The following is a description of a gene set: studied in species Homo sapiens Occular cell types curated from Gautam and Hamashima et al. Multi-species single-cell transcriptomic analysis of ocular compartment regulons from publication Gautam P, Hamashima K, Chen Y, Zeng Y, Makovoz B, Parikh BH, Lee HY, Lau KA, Su X, Wong RCB, Chan WK, Li H, Blenkinsop TA, Loh YH (PMID 34584087) Human Gene Set: GAUTAM_EYE_CORNEA_MELANOCYTES, and this is the list of marker genes: ELOVL5, PTMA, TMEM101, SUGT1, NPC2, DUSP14 (NCBI Gene Id 116242), MRPS18B, FIGN, UBE2B, CTSA, PTPN18, YTHDC1, CMTM3, MTURN, CTH, TP53BP2, PTRH1, UBE2D1, SNX3, TUBA1B, PLXNB1 (plexin B1), PRMT2, PSMD13, POLR1F, GNG5, MEF2C, NDUFAF3, RABIF, RPS8, SEM1, MGA, IFRD1, NRCAM, HYCC1, MAP4, GMFB, CYBA, EIF5, TP53RK, COPS6, FADS1, ISYNA1, DYNC2I2, DNAJC8, RPN2, C7orf50, RPL13A, SNRPC, PLIN2, BABAM1, UBALD2, TMED9, OAT, RBM3, ARHGDIA, KLF9, ITPK1, BLVRB, RPSA, ARID5B, RPL18A, CYC1, CHCHD3, SUPT4H1, LIX1L, ABL2, STAT2, RAMP1, CAVIN1, CLEC11A, MRPL28, SLC25A25, YWHAH, MID1IP1, RPL39, CFAP97, TDRD7, RPS26, RSRP1, NR3C1, NDUFAF4, ARHGEF37, POU3F3, CUTA, S100A1, LHFPL2, ALDH7A1, CCDC124, JADE1, ZNF24, LAP3, CDH1, SNRNP25, ADD3, LAMP2, RPL8, STXBP1, DNAJB1, RPS10, CD320, METRN, CHMP1A (NCBI Gene Id 5642), RTN2, CLASP2, FXYD5, NFATC2, PPM1B, RASGEF1B, TMED10, SPP1, EIF4B, KIFC3, RPS11, ISCA1 (NCBI Gene Id 92236), AZGP1, CHCHD2, RASSF3, MYO1C, SDHAF3, CCT6A, MICAL3, RPS3A, DNAJB9, GUCD1, ARL6IP5, MOB1B, LAMTOR4, IFFO1, UBE2S, PGRMC2, XRCC6, WDR18, SERTAD1, DIPK1C, TFPT, JAGN1, OLFM1, PRPF6, NPM1, PA2G4, NUBP2, FUS, CSGALNACT1, NTAN1, ARHGAP42, RPL10, ANKRD39, NAMPT, PLD3, SLC25A11, PSMC2, SRM, DDOST, PSMA7, RPL32, HSF4, C1orf43, RBBP6, CMTM6, EMC7, RPS5, QDPR (NCBI Gene Id 5860), RPS14, NEU1, RWDD1, GALK1, HOXB7, STOML2, NAT14, UROD, CCT2, CLTA, HSPG2, POLDIP3, UBA6-DT, GRN, NT5C, IMPDH2, TRAF2, CFL1, ATP6V1B2, NME1, GSTO1, TMBIM6, RPL26, TRAPPC2B, A1BG (alpha-1-B glycoprotein), EIF3G, HS1BP3, AHCYL2, PRDX4, ATOX1, PHB2, EHD4, CCN3, SEPTIN7, CSPG4, HADHA, PKIG, NUDT2, PRCP, NUCB1, SRFBP1, SAP30, SND1 (NCBI Gene Id 27044), NAP1L1, TMEM179B, WDR81, CCSER2, ETNK1, RSL1D1, POGZ, RPL12, SLC25A36, RRAGD, CHP1, HPS1, UQCRC2, TRPV2, DOCK7, TALDO1, TMEM87A, SNX7, PPIB, EDF1, BCLAF1, ERP29, RPS28, CERS1, SRP14, MRPL24, PRXL2C, FZD9, RPL19, TLN1, ASB11, CIRBP, EIF3F, GPSM3, PSMG1, RPS13, SLC27A1, UBXN2A (NCBI Gene Id 165324), NDUFB4, IFI16 (NCBI Gene Id 3428), PITPNA-AS1, RPL17, ARPC1A, CNN3, HMOX2, KIAA0930, LAMA4, SNRPA1, PARVA, RNF14, MT-ND1, PPP1CA, ECH1, BAMBI, MFGE8, EEF1B2